Given this list of marker genes CDC37, HSP90AA1, ERBB2, ERBIN, here is a description of the gene set: studied in species Homo sapiens Reactome Pathway: Resistance of ERBB2 KD mutants to trastuzumab part of: Drug resistance in ERBB2 KD mutants This pathway describes resistance of ERBB2 KD mutants to therapeutic antibody trastuzumab (herceptin).